Given this list of marker genes Eef1ece2, Ackr2, Edn2, Sstr3, Ccl28, Ednrb, Uts2, Npb, Ccl5 (C-C motif chemokine ligand 5), Ccr10, Cxcr3, Uts2r, Ccl6, Kiss1, Cort, Hebp1, Nms, Ccr7, Aplnr, Fpr1, C3, Penk, Grp, Galr3, Mc1r, Trhr, Cxcr6, F2rl3, Pf4, Pnoc, Prokr1, Sstr2, Edn3 (endothelin 3), Qrfp, Psap, Mc2r, Cxcl3, Npffr1, Ccl17, Cckar, Trh, Rln3, Ccl11, Sstr1, Ccr3, Pyy, Cxcr4, Mc3r, Mc4r, Ccl19, Oprd1, Ccl7, Ackr4, Ccr6, Rxfp2, Hcrtr2, Mchr1, Nts, Ntsr2, Avpr2, Pomc, Prlhr, Cxcr1, Nmu, Cxcl12, Cxcl10, Ccl3, Kiss1r, Qrfprl (NCBI Gene Id 243407), Hcrt, Fpr-rs7, Hcrtr1, Cckbr, Rxfp4, Agtr2, Ccl4, Galr1, Cxcr5, Cxcl2, Npsr1, Fpr-rs6, Sst, F2, Edn1, Uts2b, Bdkrb1, Cxcl16 (C-X-C motif chemokine ligand 16), Insl5, Avpr1b, Oprl1, Fpr-rs4 (formyl peptide receptor, related sequence 4), Npy2r, Hc, Mc5r, Npw (neuropeptide W), Sstr4, Ppy, Ccl9, Avp, Gper1, Gal, Brs3, Tacr2, Npy1r, Npy4r, Avpr1a, Tacr1, Ece1, Prokr2, Xcr1, Nmur1, Cx3cr1, Oprm1, Ccl21e (NCBI Gene Id 100504239), Cxcr2, Nmur2, Cxcl1, F2rl1, Grpr, Oxt, Cck, Npff (NCBI Gene Id 54615, neuropeptide FF-amide peptide precursor), Prok1, Rxfp3, Ccl21f, Galr2, Ccl12 (C-C motif chemokine ligand 12), Kel, C5ar2, Ccl21a, Ccl20, Ccr8, Tac2 (tachykinin 2), Ccr4, C3ar1, Ntsr1, Bdkrb2, Fpr-rs3, Nmb, C5ar1, Cxcl9, Prok2, Oxtr, Kng2, here is a description of the gene set: part of: Class A/1 (Rhodopsin-like receptors) studied in species Mus musculus This event has been computationally inferred from an event that has been demonstrated in another species.<p>The inference is based on the homology mapping from PANTHER. Briefly, reactions for which all involved PhysicalEntities (in input, output and catalyst) have a mapped orthologue/paralogue (for complexes at least 75% of components must have a mapping) are inferred to the other species. electronically inferred by orthology from the curated human pathway Reactome Pathway: Peptide ligand-binding receptors